The following is a description of a gene set: Human Gene Set: HP_ASYMMETRY_OF_SPINAL_FACET_JOINTS species: Homo sapiens Asymmetry of spinal facet joints, and this is the list of marker genes: VANGL1, VANGL2, FUZ, CCL2, TBXT